The following is a description of a gene set: Genes down-regulated in naïve CD8 T cells compared to memory CD8 T cells (day 40+ after LCMV-Armstrong infection). Human Gene Set: KAECH_NAIVE_VS_MEMORY_CD8_TCELL_DN from publication Kaech SM, Hemby S, Kersh E, Ahmed R (PMID 12526810) species: Homo sapiens How and when memory T cells form during an immune response are long-standing questions. To better understand memory CD8 T cell development, a time course of gene expression and functional changes in antigen-specific T cells during viral infection was evaluated. The expression of many genes continued to change after viral clearance in accordance with changes in CD8 T cell functional properties. Even though memory cell precursors were present at the peak of the immune response, these cells did not display hallmark functional traits of memory T cells. However, these cells gradually acquired the memory cell qualities of self-renewal and rapid recall to antigen suggesting the model that antigen-specific CD8 T cells progressively differentiate into memory cells following viral infection., and this is the list of marker genes: FOS, TENT5C, HS1BP3, RPAP1, RECK, DPP7, CAPNS1, TXN, UNC119, FGF19, SORL1, RPGR, EEA1, PFKP, KLRK1, PHF13, ST3GAL6, FCGRT, POLR2L, KLF6, GSTO1, FGF13, SLC25A53, FGL2, HLA-A, CTSW, ITGB2, PACS1, HDHD5, SNTB2, PPP3CC, N4BP1 (NCBI Gene Id 9683), MYO1F, CASP1, PON1, ZMAT3, GADD45B, GDNF, CHPT1, FCGR2B (NCBI Gene Id 2213), F2R, CTLA4, SNX10, CCR5, MAP7D1, GLRX, SLCO3A1, CAPN2, ST3GAL4, MAPRE2, YES1, CRTAM, EMP1, S100A4, ID2, MOGS, LYSMD2, SH3YL1, S100A13 (NCBI Gene Id 6284), ACOT7, HMGB2, CST7, ITGB1, IFNG, LGALS1, DENND5A, CDC34, S100A6, STARD10, ITGAX, LRRC8C, MBD2, TRAPPC1, PCNA (NCBI Gene Id 5111), IL7R, CCR2, IL18R1, GZMM, DYM, HASPIN, CD44, ETFB, ITGB7, TNFRSF1B, H1-0, CTSD, ST8SIA2, ODC1, RACGAP1, ATN1, IQGAP2, TXNDC5, MTMR7, IFITM10, OPRK1, ANXA2, EOMES, PRSS12, CLDND1, TTC7B, TOB1, DPM3, FOSB, KLF10, CYFIP2, SH2D1A, BCL2, ADGRE5, PRF1, SF3A1, PIM1, GGH, IGF2R, NELFE, PGLYRP1, PLSCR1, NUCB1, SYT9, KRTCAP2, ARL6, FRMD5, CCND3, XDH, BHLHE40, JUND, KLRC1, SH2D2A, CRIP2, RAD51D, IL10RA, HCFC1R1, CXCR3, GATA3, RBMX, DAPK2, PGAM1, BCL2A1, PRR13, TMED10, MX2, EFHD2, BCHE, RNF138, ATF6, WEE1 (WEE1 G2 checkpoint kinase), TOM1, NRP1, DOCK5, FASLG, ANXA1, GZMB, VKORC1, CCL4, AQP9, UNC119B, KLRG1, SEPTIN1, UBC, CISH, KLF4, GZMK, ITGA4, CDK4, ADAM19, S100A10, PRDX2, IL18RAP, RNF19B, GABARAPL2, TBL2, BAG3, FGR, SHC1, GBP4, TSPAN31 (NCBI Gene Id 6302), S100A11, ERRFI1, LYPLA2, ELL2 (NCBI Gene Id 22936), PTPN13, CD160, RORA, CD7, TNFSF10, XRCC5, CCL5, CTNNA1, AHNAK, STMN1, CASP4, MDFIC, PCLAF, HOPX, KCNJ8, CYB5R3, COX17, YBX3, POU6F1, TNFAIP3, TMEM37